Given this list of marker genes MLXIPL, FASN, AGPAT1, ACACB, ACACA, MLX, ACLY, PKLR, here is a description of the gene set: studied in species Homo sapiens ChREBP activates metabolic gene expression Human Gene Set: REACTOME_CHREBP_ACTIVATES_METABOLIC_GENE_EXPRESSION